The following is a description of a gene set: species: Homo sapiens The aim of this study was to quantify the impact of chimeric Foxp3-GFP protein on the Treg cell transcriptional program. Genes up-regulated in Foxp3-ires-GFP T conv (FOXP3-): B6 versus NOD background. Human Gene Set: GSE37605_C57BL6_VS_NOD_FOXP3_IRES_GFP_TCONV_UP from publication Darce J, Rudra D, Li L, Nishio J, Cipolletta D, Rudensky AY, Mathis D, Benoist C (PMID 22579475), and this is the list of marker genes: ENPEP, PPP1R3G, SPACA5, RYR2, GLT8D1, CYP2E1 (cytochrome P450 family 2 subfamily E member 1), PDLIM7, LSM12, WDR35, SYNJ2, FCRL5, PLK5, IFT88, MTREX, CALCR, PPFIBP1, WDR11, GPR119, STIM2, ERMP1, AICDA, POLA1, CDC14A, SH3GL3, DNASE1L3, MAPRE3, GABARAPL1, IL13RA1, IFT52, GUCY1B1, TMEM38B, SYNPO, TNIP2, CD226, PEX2, SLC9A7 (solute carrier family 9 member A7), IRF8, CXCR5, ADGRD1, VEGFC, MARCKSL1, NYNRIN, REEP3 (NCBI Gene Id 221035), JAZF1, GUCY1A1, DSTYK, ACOT12, ADARB1, PTCH1, HECTD2, SYTL4, TMEM63C, GPA33, GPR26, CACNG4, AGBL1, CCR6, TCEAL9, PLPP1, TNFSF13B, TRAM2, TOR3A, NPAS4, B3GNT2, CEBPA, FCGR3A, PLCXD3, HEY1, NUP93, INPP5F, GPRIN3, GPR45, GZF1, DDC, MFSD13A, ARHGAP24, CFAP251, CRELD2, CAMK2D, SCIN, SYNJ1, IFITM2, INPP5B, TGFBR1, PDE7A, TIMP2, GEMIN8, INSRR, HMOX1, TMEM65, ANKAR, MRTFB, OPN3, IGSF9, GLRA1, FAM162A, ME1, TSPAN5, NF1, IL1F10, SPEM1, FAM81A, TBC1D12, FHDC1 (NCBI Gene Id 85462), KIF18A, HYAL6P, ASNSD1, GNA14, CHST15, IMMP2L, SLIT1, LIMS1, NCOA1, ALDH5A1, STON2, CAPN11, HIVEP3, SERPINC1, PRKCA, PAPPA, CNNM2, FGD6, UAP1L1, EXPH5, DSCAM, GHITM, FCMR, ATP1A3, NTRK3, BCAT1, PDCD1LG2, STARD10, SH3RF2, MYO3B, MAP3K5, POU2AF1, DCLRE1A, MIR103A1, PXMP2, PGAP6, SCAMP1, ABCD3, CGRRF1